Given this list of marker genes Cd36 (NCBI Gene Id 12491), Acsl4, here is a description of the gene set: Reactome Pathway: Intracellular metabolism of fatty acids regulates insulin secretion species: Mus musculus electronically inferred by orthology from the curated human pathway part of: Free fatty acids regulate insulin secretion This event has been computationally inferred from an event that has been demonstrated in another species.<p>The inference is based on the homology mapping from PANTHER. Briefly, reactions for which all involved PhysicalEntities (in input, output and catalyst) have a mapped orthologue/paralogue (for complexes at least 75% of components must have a mapping) are inferred to the other species.